The following is a description of a gene set: A cellular organelle, found close to the nucleus in many eukaryotic cells, consisting of a small cylinder with microtubular walls, 300-500 nm long and 150-250 nm in diameter. It contains nine short, parallel, peripheral microtubular fibrils, each fibril consisting of one complete microtubule fused to two incomplete microtubules. Cells usually have two centrioles, lying at right angles to each other. At division, each pair of centrioles generates another pair and the twin pairs form the pole of the mitotic spindle. Mouse Gene Set: GOCC_CENTRIOLE studied in species Mus musculus, and this is the list of marker genes: Ttc8, Hspa1b, Tubgcp3, Rab34, Mks1 (NCBI Gene Id 380718), Dzip1, Ccnf, Ccdc68, Cep295nl (CEP295 N-terminal like), Tssk2, Micall1, Ahi1, D7Ertd443e, Ccdc120, Cep89, Cep350, Birc5 (NCBI Gene Id 11799), Ccp110, Neurl4, Fbxw8, Cep78, Crocc2, Saxo2, Sass6, Cep63, Herc2, Agbl3, Dnm2 (dynamin 2), Tubd1, Nedd1, Cchcr1, Cntrob, Ift81, Alms1, Fam161a, Ppp1r35, Cep76, Sdccag8, Cep135, Cep164, Tubg1, Crocc (ciliary rootlet coiled-coil, rootletin), Cetn3, Odf2 (NCBI Gene Id 99090), Bnip2, Ssna1, Cep104, Atxn10, 2700049A03Rik, Deup1, Cep162, Htt, Ccsap, Ccdc15, Cep170, Saxo1, Magi2, Ttbk2 (NCBI Gene Id 98929), Cep41, Dctn1, Cetn2, Tsga10, Washc1, Rabl2, Ift140, Cep120, Enkd1, Fbf1, Rilpl1, Intu, Spice1, Cplane2, Bbs4, Cep55, Cep295, Cep192, Cetn4 (centrin 4), Akna, Cibar1, Cenpj, Nphp4, Nin, Ccdc146, Sirt2, Ofd1, Cep290, Stard9, Agbl4, Plk1, Capg, Ftcd, Cibar2, Wdr62, Hspa1a, Kif24, Rab11a, Cetn1, Cep83, Sfi1, Cep43, Cep44, Ift43, Odf2l (outer dense fiber of sperm tails 2-like), Mdm1, Rab8a, Cep20, Actr1a, Cep250, Cep19, Cby1, Ift88, Aurka, Rock1, Rp2, Cep97, C2cd3, Mphosph9 (M-phase phosphoprotein 9), Poc1a, Topors, Ccdc78, Gle1, Top2a, Poc1b, Nubp1, Rttn, Pcm1, Pla2g3, Dync2i2, Ran, Nubp2, Hap1, Tedc2, Ift52, Bccip, Parp3, Cntln, Poc5, Smo, Mapk15, Plk2, Tsks, Agbl2, Odad3, Pcnt, Ift20, Cep152, Hyls1, Cep128, Stil, Ccdc88a, Cep131, Dzip1l, Armc9, Ccdc92, Cep85, Sclt1, Plk4, Tedc1, Ccdc57, Kif3a, Wdr90 (NCBI Gene Id 74017), Lrrcc1, Cfap20